The following is a description of a gene set: Human Gene Set: REACTOME_DEFECTIVE_CSF2RB_CAUSES_SMDP5 Defective CSF2RB causes SMDP5 studied in species Homo sapiens, and this is the list of marker genes: SFTPA2, CSF2RA, CSF2RB, SFTPD, SFTPB, SFTPC, SFTPA1, SFTA3